Given this list of marker genes BCL2L13, BEX3, APAF1, CASP1, NLRP1, CTSH, RACK1, NOD1, ATP2A3, NKX3-1, BAD, NGF, CASP8AP2, here is a description of the gene set: Binds to and increases the rate of proteolysis catalyzed by a cysteine-type endopeptidase involved in the apoptotic process. Human Gene Set: GOMF_CYSTEINE_TYPE_ENDOPEPTIDASE_ACTIVATOR_ACTIVITY_INVOLVED_IN_APOPTOTIC_PROCESS species: Homo sapiens